The following is a description of a gene set: The process whose specific outcome is the progression of the stomach over time, from its formation to the mature structure. The stomach is an expanded region of the vertebrate alimentary tract that serves as a food storage compartment and digestive organ. Mouse Gene Set: GOBP_STOMACH_DEVELOPMENT studied in species Mus musculus, and this is the list of marker genes: Kcnq1, Nkx6-3, Ascl1, Ext1, Hes1, Nphp3